The following is a description of a gene set: from publication Tabula Muris Consortium (PMID 32669714) Mouse Gene Set: TABULA_MURIS_SENIS_KIDNEY_KIDNEY_COLLECTING_DUCT_EPITHELIAL_CELL_AGEING species: Mus musculus, and this is the list of marker genes: Ctsd, Akr7a5, Ndrg2, F11r, Tprkb, Slc39a6, Ptms, Ybx1, Cfl1, Neat1, Malat1, Tle5, Cst3, Tmx4, Rpl13a, Sdhc, Spink1, Pebp1